Given this list of marker genes VCP, RILPL1, GNE, CRPPA, STAC3, ANXA11, RTN2, MEGF10, RNF31, POMT1, PNPLA2, ANO5, TTN, ADSS1 (NCBI Gene Id 122622), FLNC, PABPN1, FKRP, HNRNPA2B1, LMOD3, MYOT, GIPC1, CFL2, CAPN3, KCNE3, DNAJB6, SMPX, FXR1, CACNA1S, SCN4A, POGLUT1, TNNC2, PMP2, ITGA7, FLAD1, POPDC3, MYH14, FKTN, SECISBP2, HNRNPA1, COL6A1, NEB, here is a description of the gene set: Fatty replacement of skeletal muscle Muscle fibers degeneration resulting in fatty replacement of skeletal muscle fibers Human Gene Set: HP_FATTY_REPLACEMENT_OF_SKELETAL_MUSCLE studied in species Homo sapiens